The following is a description of a gene set: from publication Rivollier A, He J, Kole A, Valatas V, Kelsall BL (PMID 22231304) Dendritic cells (DCs) and macrophages (MPs) are important for immunological homeostasis in the colon. We found that F4/80hi CX3CR1hi (CD11b+CD103-) cells account for 80% of mouse colonic lamina propria (cLP) MHC-IIhi cells. Both CD11c+ and CD11c- cells within this population were identified as MPs based on multiple criteria, including a MP transcriptome revealed by microarray analysis. These MPs constitutively released high levels of IL-10 at least partially in response to the microbiota via an MyD88-independent mechanism. In contrast, cells expressing low to intermediate levels of F4/80 and CX3CR1 were identified as DCs, based on phenotypic and functional analysis and comprise three separate CD11chi cell populations: CD103+CX3CR1-CD11b- DCs, CD103+CX3CR1-CD11b+ DCs and CD103-CX3CR1intCD11b+ DCs. In non-inflammatory conditions, Ly6Chi monocytes differentiated primarily into CD11c+, but not CD11c- MPs. In contrast, during colitis, Ly6Chi monocytes massively invaded the colon and differentiated into pro-inflammatory CD103-CX3CR1intCD11b+ DCs, which produced high levels of IL-12, IL-23, iNOS and TNF. These findings demonstrate the dual capacity of Ly6Chi blood monocytes to differentiate into either regulatory MPs or inflammatory DCs in the colon, and that the balance of these immunologically antagonistic cell types is dictated by microenvironmental conditions. Human Gene Set: GSE27859_DC_VS_CD11C_INT_F480_INT_DC_UP Genes up-regulated in dendritic cells versus those sorted as ITGAX int and EMR1 int. species: Homo sapiens, and this is the list of marker genes: GSTK1, MGLL, LPXN, TYK2, AOPEP (aminopeptidase O (putative)), POLM, SNAP25, METRNL, CBR1, DRC3, GNA13, PDE1C, MGMT, PGS1, MYO1F, BAZ2A (bromodomain adjacent to zinc finger domain 2A, NCBI Gene Id 23525), MALAT1, MOB2, PDE6H, NABP1, SUCLG1, SIRT2, SELENOV, RIOK3, PDE4B, RFXANK, ADAM8, TNFRSF9 (TNF receptor superfamily member 9), KRT1, TMEM234, AFF4, CMIP, GNPTAB, NSF, BSCL2, ATOSB, CHST12, PRDM1, GJD2, OGA, RPS27, TARBP2, ANKS3, ECI2, BCKDHA, STAT3, SRI, NR1H3, CLDN2, APAF1, IL16, OIT3, SLC17A2, C3orf38, TLR4, CILK1, FCGR2A, RABGAP1, SLC13A3, MAN1A2, HOXC6, YPEL5 (NCBI Gene Id 51646), ZSCAN2, DCAF15, SDR42E1, UBALD2, ZNF358, TSPAN2, PTPN2, PDGFB, SMPD1, RPS16, ADAM9, SLC35F5, PLBD1, HMG20A, FAM210B, DERL1, TSPAN5, ITGA3, RPL22 (NCBI Gene Id 65281), GABARAPL2, NEK8, ELMO2 (NCBI Gene Id 63916), RANBP10, SNCAIP, SERPINE1, RNF20, SMIM14, CTSD, FBXO28, ACAA1, SEZ6L, MED12, PARP4 (poly(ADP-ribose) polymerase family member 4), PAN2, SLK, NIPBL, KRTCAP3, TRHR, DCTN4, TEP1, SRSF5, LIMS2, ACSBG1, VAT1, ZFP91, NUDT16, TBXAS1, FAM98C, SEMA4F, VAV1, PRKN, OS9, EEIG1, DNM1 (NCBI Gene Id 1759), CD53, DUSP16, DOK1, INTS6L, MAP1LC3A, OAZ2, TMPRSS3, TMC4, TLE1, SLC25A20, PRKACA, TMLHE, ITGAL, SLC37A3, CPLX1, UBL5, CACFD1, FOXO1, PAXBP1, STAT5A, CYP11A1, NME5, CNPPD1, MESP2, CYP1A1, ZKSCAN1, BMPR1A (NCBI Gene Id 8035), DYM, NMB, SGMS1 (sphingomyelin synthase 1), JUNB, EIF3F, KLKB1 (NCBI Gene Id 3818), ZBTB7A, LIMD1, CYBC1, FAM117B, IL4R, WAC, MAF1, RNF19A (NCBI Gene Id 81036, ring finger protein 19A, RBR E3 ubiquitin protein ligase), SH3BGR, TPRA1, STK26, TBX6, IRF6, MAGI3, APLP1, EPAS1, RPS21, MINK1, CCDC28A, IDH1, SLC25A51, HIF3A, DVL2, USE1, RUNX3, GALNT10, EFEMP2, SLC2A8, ZNF790, PDCD4, CYP2F1, GPX3, XPA, PI4KA, RANBP9, NDRG4, KLF7, JARID2, P3H4, PTPN18, PEDS1, TMEM40, PERP, RBM39, EGLN2, RAC2, STX5, RAB4A, THY1, RPL38, RAP2A